Given this list of marker genes PDCD10, PIK3CA, KRIT1, CYP11A1, ENPP1, CCM2, ABCC6, LIPA, here is a description of the gene set: Human Gene Set: HP_ADRENAL_CALCIFICATION species: Homo sapiens Adrenal calcification Calcification within the adrenal glands.